Given this list of marker genes Axin1, Tcf7l1, Rpl38, Zic3, Foxh1, Epb41l5, Nog, Zic2, Nodal, Epha2, Poglut1, here is a description of the gene set: Mouse Gene Set: GOBP_AXIAL_MESODERM_DEVELOPMENT The process whose specific outcome is the progression of the axial mesoderm over time, from its formation to the mature structure. The axial mesoderm includes the prechordal mesoderm and the chordamesoderm. It gives rise to the prechordal plate and to the notochord. species: Mus musculus